Given this list of marker genes Inpp5e, Inpp5k, Inpp5d, Synj1, Inppl1, Inpp5j, Inpp4a, Inpp1, Minpp1, Inpp4b (inositol polyphosphate-4-phosphatase, type II), Inpp5b, Inpp5a, Ocrl, Synj2, here is a description of the gene set: Mouse Gene Set: GOMF_INOSITOL_TRISPHOSPHATE_PHOSPHATASE_ACTIVITY Catalysis of the reaction: myo-inositol trisphosphate + H2O = myo-inositol bisphosphate + phosphate. studied in species Mus musculus